Given this list of marker genes FCGR3A, C1QTNF2 (NCBI Gene Id 83845), HOXB6, BDNF, IGHMBP2, SGCA, PSENEN, SLC35G6, RFX5, GOLGA8M, DNA2, ATP1A3 (NCBI Gene Id 95633), RELL1, IRF3, ART1, SEPTIN5, MEGF8, PRDM9, RGS10, IDH3B, HRH1, FKBP5, PMEPA1, PTK6, LSP1, OR51D1, DPF1, GUK1, SPRYD3, DDIT4, TBC1D21, TPRA1, GMPPB, EXOG, UBXN6, MED1 (NCBI Gene Id 9327), PDRG1, ATP6AP1L, HMCES, R3HDM4, CRLF2 (cytokine receptor like factor 2), MYG1, CMTM3, SAP30, KCNJ10, GFRA4, ACTRT1, ZNF580, MEGF10, FRA10AC1, ITPRIPL1 (NCBI Gene Id 150771), TSC22D3, SLC25A39, UBL4A, PTPN7, PRR5 (NCBI Gene Id 86335), LYL1, UBB, ST13P4, SLC39A13, FGF23, DDX19A, B4GALT3, here is a description of the gene set: Genes down-regulated in blood 6hr vs 0hr in adults (18-45) after exposure to CN54gp140 adjuvanted with GLA-AF, time point 6H, administered i.m. from publication Anderson J, Olafsdottir TA, Kratochvil S, McKay PF, Östensson M, Persson J, Shattock RJ, Harandi AM (PMID 29535712) Systems biology approaches have recently provided new insights into the mechanisms of action of human vaccines and adjuvants. Here, we investigated early transcriptional signatures induced in whole blood of healthy subjects following vaccination with a recombinant HIV-1 envelope glycoprotein subunit CN54gp140 adjuvanted with the TLR4 agonist glucopyranosyl lipid adjuvant-aqueous formulation (GLA-AF) and correlated signatures to CN54gp140-specific serum antibody responses. Fourteen healthy volunteers aged 18-45 years were immunized intramuscularly three times at 1-month intervals and whole blood samples were collected at baseline, 6 h, and 1, 3, and 7 days post first immunization. Subtle changes in the transcriptomic profiles were observed following immunization, ranging from over 300 differentially expressed genes (DEGs) at day 1 to nearly 100 DEGs at day 7 following immunization. Functional pathway analysis revealed blood transcription modules (BTMs) related to general cell cycle activation, and innate immune cell activation at early time points, as well as BTMs related to T cells and B cell activation at the later time points post-immunization. Diverse CN54gp140-specific serum antibody responses of the subjects enabled their categorization into high or low responders, at early ( < 1 month) and late (up to 6 months) time points post vaccination. BTM analyses revealed repression of modules enriched in NK cells, and the mitochondrial electron chain, in individuals with high or sustained antigen-specific antibody responses. However, low responders showed an enhancement of BTMs associated with enrichment in myeloid cells and monocytes as well as integrin cell surface interactions. Flow cytometry analysis of peripheral blood mononuclear cells obtained from the subjects revealed an enhanced frequency of CD56<sup>dim</sup> NK cells in the majority of vaccines 14 days after vaccination as compared with the baseline. These results emphasize the utility of a systems biology approach to enhance our understanding on the mechanisms of action of TLR4 adjuvanted human vaccines. studied in species Homo sapiens Human Gene Set: ANDERSON_BLOOD_CN54GP140_ADJUVANTED_WITH_GLA_AF_AGE_18_45YO_6HR_DN